Given this list of marker genes GRP, HAMP, GRB10, SUMO1, MIR133B, GPR35, MCUB, AKT1, TNF, MIR24-1, CTTNBP2NL, MIR29B1, SLN, OSTN, CTNND1, MIR326, OAZ2, GOPC, MIR873, KCNQ1, PPP3R1 (protein phosphatase 3 regulatory subunit B, alpha), MIR30D, MIR185, NEDD4L, CRBN, OSR1, SESTD1, CAV1, YWHAQ, IL1B, MIR200C (NCBI Gene Id 406985, microRNA 200c), GSK3A, PEA15, CALM1, PPP3R2, MIR495, KCNE2, MIR129-1, SLC30A1, MIR1-1 (NCBI Gene Id 406904), ATP1A2, CALCA, ENPP1, MIR451A, EPO, MIR192, MIR448, PRKCB, PRKCE, KCNE3, APPL2, KCNAB1, MIR133A1, MIR34A, NOS1, TMBIM6, PCSK9, PID1, CALM2, KEL, PPIF, RGS4, CRHR1, ANK3 (NCBI Gene Id 288), UBR3, TGFB1, INPP5K, CBARP, OAZ1, CAV3, MIR508, NEDD4, MIR107, MIR143, UCP2, ARL6IP5, SELENOS, LEP, STK39, MIR328, COMMD1, FKBP1B, CERS1, KCNE5, AKT2, MIR26A1, MIR208A, YWHAE, NTSR1, IRS2, MIR34B, SLC43A2, MIR9-1, ISCU, CACNA1F, KCNRG, FABP5, PPP3CA, RSC1A1, BCL2, MIR208B, OAZ3, THBS1, SIRT6, WWP2, MIR212, SLC26A5, AGT, CLDN3, PPP3CB, KCNE1, REM1, MMP9, UBQLN1, CAB39, VDAC1, CAMK2D, TCAF2, GNB5, MIR499A, CALM3, PLN, SLC43A1 (solute carrier family 43 member 1), PPP3CC, RGS2, BIN1, GSTO1, OXSR1, MIR103A1, MIR186, TLR9, STXBP3, KCNH2, FMR1, here is a description of the gene set: Any process that stops, prevents, or reduces the frequency, rate or extent of the directed movement of a solute from one side of a membrane to the other. Human Gene Set: GOBP_NEGATIVE_REGULATION_OF_TRANSMEMBRANE_TRANSPORT species: Homo sapiens